The following is a description of a gene set: species: Homo sapiens Human Gene Set: AREB6_03 Genes having at least one occurrence of the motif VNRCACCTGKNC in the regions spanning 4 kb centered on their transcription starting sites. This matches the TCF8 transcription factor binding site V$AREB6_03 (v7.4 TRANSFAC)., and this is the list of marker genes: SSH3, SRSF7, NGFR (nerve growth factor receptor), CCDC78, CAVIN2, KCNK16, EBF1, NUMBL, AHR, VAT1, ADAM12, DSG2 (NCBI Gene Id 1829), WDR5, LMNTD2 (lamin tail domain containing 2), SH2D3C, PPP1R14C, TEC, BRSK1, SSX2IP, EYA1, USP46, DST, LIMK2, SHKBP1, NKAIN4, YIPF6, IGF2, CTNNBIP1, HOXA11, ELMO1, RIPK4, MAPK14, GNA12, CHRM1, CXCR4, NFE2, GRHL3, ACTA1, IGF2-AS, USP15, LRP5, PARD6A, ZNF503, DLG2, NAT8L, REM2, LRCH4, CRELD1, ARHGEF38, ATF6, SLC48A1, CDH3, NRF1, BCL7A, HSALR1, SEMA4G, HCRTR1, FGF9, IL4, FAM117B, SMTN, PPTC7, C12orf42, S1PR1, PDE1C, SLC16A6, SLC30A3, IKZF2, HNF4A, PAQR5, GPD1, PDE11A, KCNJ11, ROCK1, NCOR1, SPEG, E2F1, LAMC2, DSCAML1, TECTA, LARP1B, PPP1R16B, TOX2, KIF1C, FCMR, NHSL2, SNAP25, NTRK3, POU4F2, ITGB4, PRMT3, APP, SYT2, HDAC3, HSP90B1, MRPL14, JAG1, GLI1, TSPAN33, TRAK2, FST, SSBP3, KLHL23, PYM1, SERF2, CBX8, SSBP4, DSCAM, CIZ1, AP1S2, TLX2, NPNT, LSP1, MMP16, DSTN, LIMA1, DNMT3A, CD2AP, CAMTA2, FUT8, PNOC, DMD, MRTFA, FGF8, SIK2 (salt inducible kinase 2), MID1IP1 (NCBI Gene Id 58526), MEIS2, ARHGAP26, ADGRG6, PLCB2, ZNF462, EPCAM, VSX2, ANKRD13B, TACC2, DMXL1, RELL2, LLGL2, MPC2 (NCBI Gene Id 25874), DGKZ, SCN3B, KRT8, CYRIA, ZEB1, CCL20, MACROH2A1, AKTIP, RPS6KB1, NECTIN4, LMO3, PLEKHH3, IRF6, CRB3, MTUS1, FITM1, RNF182, REPIN1, HMCN1, JAKMIP1, IL17C, MEGF8, WWC2-AS2, ITGA6, SLC7A11, CUEDC1, MED26, SCUBE2, SLC9A7, ASIC4, NBEA, NGF, RHBDF2, CTNND1, DOK7, PLAGL2, PDGFA, HNF1B, FRMD5, KREMEN2, PIM2, SYVN1, LRRN1, ATXN1, CHRNB1, DENND4A, AJUBA, SKAP1, NR4A2, LARP4, THRA, RGMA, SPMIP9, SLC44A1, ZNF710, IL1RAPL1, PHACTR3 (NCBI Gene Id 85418), KLHL1, WDR6, CRMP1, DDAH1, PPM1J, TNNT3, EHD1, KHDRBS2, GNG8, PSD3, PNCK, JMJD1C, MARCKSL1, MLLT3, TNNI1, LYL1, DOC2A, TSPAN2, ELL3, MINK1, DGKA, ERP29, FAF1, PHF1, TIMM10B, ALX3, FOXA1, DNMT3B, PRR15, LPAR1, DIO2, VGLL4, ERBB3, POU4F1, STRADB, CACNB3, CHAC1, BICDL1, ARFIP2, OSR1, POFUT1, CEL, FBXO24, MYH10, RIMKLA, STARD13, PCYOX1L, GHDC, SCNN1G, TLNRD1, PNKP, ARTN, EXTL3, NPEPPS, MAB21L1, FA2H, LRRC8D, LSR, RASSF7, FLNB, L3MBTL2, CCKAR, SLC24A3, CDK14 (cyclin dependent kinase 14), ENHO, SEMA3F, DNAH17, TMEM116, FGR